Given this list of marker genes Map2k7, Ift25, 5730409E04Rik, Palld, Phldb2 (pleckstrin homology like domain, family B, member 2), Ncl, Eif3e, Dynlt3, Cenpb, Inpp1, Hmgn5, Xaf1, Trp53inp2, Lzts3, Nbeal1, Gm14325, Trak2, Anp32b, Ccdc34, Rbis, Rassf3, Cyb5r3, Naa50, Ccng1, Akap12, Ammecr1, Ccnd2, Rab13, Dynll2, Bmi1, Ankrd11, Mtpn, Kif1c (NCBI Gene Id 237826), Atf5, Hnrnpa3, Scaper, Kif5b, Abracl, Gm4836, Ssb, Pggt1b, Pkn1, Gxylt1, Fbxo32, Map1b, Matr3, Gm14288, Apobr, Pkp4, Gab2, Trim12c, Eif3a, Dcaf5, Zeb2, Golga4, Nap1l1, Ppfia1, Sh3pxd2a, Klhl12, Vcpip1, Upf3a, Coa5, Rflnb, Dkc1, Kctd10, Samd4, Kank2, Pdap1, Gltp, Bbip1, Eif2s2, Mff, Ddr2, Sh3bgrl, Septin7, Cplx2, Rgs20, Zbtb12, Cmc1, Igip, Cox20, Eif2a, Htatsf1 (HIV TAT specific factor 1), Apc, Zeb1, here is a description of the gene set: RNA localization is important for the establishment and maintenance of polarity in multiple cell types. Localized RNAs are usually transported along microtubules or actin filaments and become anchored at their destination to some underlying subcellular structure. Retention commonly involves actin or actin-associated proteins, although cytokeratin filaments and dynein anchor certain RNAs. RNA localization is important for diverse processes ranging from cell fate determination to synaptic plasticity; however, so far there have been few comprehensive studies of localized RNAs in mammalian cells. Here we have addressed this issue, focusing on migrating fibroblasts that polarize to form a leading edge and a tail in a process that involves asymmetric distribution of RNAs. We used a fractionation scheme combined with microarrays to identify, on a genome-wide scale, RNAs that localize in protruding pseudopodia of mouse fibroblasts in response to migratory stimuli. We find that a diverse group of RNAs accumulates in such pseudopodial protrusions. Through their 3' untranslated regions these transcripts are anchored in granules concentrated at the plus ends of detyrosinated microtubules. RNAs in the granules associate with the adenomatous polyposis coli (APC) tumour suppressor and the fragile X mental retardation protein (FMRP). APC is required for the accumulation of transcripts in protrusions. Our results suggest a new type of RNA anchoring mechanism as well as a new, unanticipated function for APC in localizing RNAs. from publication Mili S, Moissoglu K, Macara IG (PMID 18451862) species: Mus musculus Transcripts enriched in pseudopodia of NIH/3T3 cells (fibroblast) in response to the chemotactic migration stimulus by lysophosphatidic acid (LPA). Mouse Gene Set: MILI_PSEUDOPODIA_CHEMOTAXIS_UP